Given this list of marker genes Map3k12, Arf4, Arc, Pde12, Pbx2, Ptgr2, Gsk3a (NCBI Gene Id 76828, glycogen synthase kinase 3 alpha), Naa50, Iba57, Etfdh, Nid1, Acadvl, Dlg4, Bcl2l13, Acaa2, St3gal2, Negr1, Tmem134, Pold4, Thoc6, Lpl, Fah, Traf7, Qtrt2, Hoxa4, Csnk1g2 (NCBI Gene Id 72764), Ech1, Hcfc1r1 (host cell factor C1 regulator 1 (XPO1-dependent)), Ccdc87, Etfb, Btf3l4, Spatc1, Cmss1, Ltbp3 (latent transforming growth factor beta binding protein 3), Nlrp4a, Zfp1006, Mgst1, Pspc1, Hsdl2, Pitpnm1, Cmpk1, Zfp655, Hsp90b1, Eci3, Ywhag, Tmed5, Slc35e3, Tarbp2, Natd1, Pnrc1, Cryzl1 (crystallin zeta like 1), Cpt2 (NCBI Gene Id 12896), Exd1, Lpcat3, Ilvbl, Tpt1, Plin1, Arrdc2, Ugt1a6a, Vim, Setdb1, Orc5, 3110009E18Rik, Rrp1b, Ucp2, Pcbp2, Crtc2, Filip1l, Acox1, Dlc1 (deleted in liver cancer 1), P3h4, Ankrd33, Cela1, Rbm4b, Klf11, Ugt1a9, Pan2, Ccdc18 (NCBI Gene Id 75724), Slc22a12, Decr1, Itsn1, Mrps33, Coq3, Hoxa3, Calhm6, Hjurp, Acads (acyl-Coenzyme A dehydrogenase, short chain), Fitm2, Tmcc3, Lmbr1, Etfa, Ttc41, Pex11g, Eci2, Pla2g15, Txnip (NCBI Gene Id 99524), Pim3, Idh1, Acadm, Scarb2, Chp1 (calcineurin-like EF hand protein 1), Acaa1a, Elmod3, Gnai2, Tom1l2, Igsf6, Zfp386, Oxsr1, Cpt1a, Ankrd46, Capn3, Ephx2, Mmrn2, Fnip1, Sf1, Micall2, Cblb, Lmbrd1, Slco1a6, Mettl9, Txndc12 (thioredoxin domain containing 12 (endoplasmic reticulum)), Elmod2, Bmp2k, Mlf2, Sncg, Spaar, Pisd-ps1, Otud5, Myd88, Proc, Dbi, Mlst8, Casp8, Lipe, Gsg1, Sec24c, Tmem87a, Serpine1, Hgh1, Il15ra, Atp6v1a, Hoxa1, Grpel1, Bfar, Ramp1, Drc3, Fkbp10, Dnajc19, Ganc, Kti12, Pxmp4, Zbtb2, Sspn, Ppp1r15b, here is a description of the gene set: Control of cell differentiation occurs through transcriptional mechanisms and through epigenetic modification. Using a chromatin immunoprecipitation-on-chip approach, we performed a genome-wide search for target genes of peroxisome proliferator-activated receptor gamma (PPAR gamma) and its partner protein retinoid X receptor alpha during adipogenesis. We show that these two receptors target several genes that encode histone lysine methyltransferase SET domain proteins. The histone H4 Lys 20 (H4K20) monomethyltransferase PR-Set7/Setd8 gene is upregulated by PPAR gamma during adipogenesis, and the knockdown of PR-Set7/Setd8 suppressed adipogenesis. Intriguingly, monomethylated H4K20 (H4K20me1) levels are robustly increased toward the end of differentiation. PR-Set7/Setd8 positively regulates the expression of PPAR gamma and its targets through H4K20 monomethylation. Furthermore, the activation of PPAR gamma transcriptional activity leads to the induction of H4K20me1 modification of PPAR gamma and its targets and thereby promotes adipogenesis. We also show that PPAR gamma targets PPAR gamma2 and promotes its gene expression through H4K20 monomethylation. Our results connect transcriptional regulation and epigenetic chromatin modulation through H4K20 monomethylation during adipogenesis through a feedback loop. Genes with promoters bound by both PPARG and RXRA at 36 h time point of adipocyte differentiation of 3T3-L1 cells (preadipocyte). Mouse Gene Set: WAKABAYASHI_ADIPOGENESIS_PPARG_RXRA_BOUND_36HR studied in species Mus musculus from publication Wakabayashi K, Okamura M, Tsutsumi S, Nishikawa NS, Tanaka T, Sakakibara I, Kitakami J, Ihara S, Hashimoto Y, Hamakubo T, Kodama T, Aburatani H, Sakai J (PMID 19414603)